Given this list of marker genes IL12B, IL23A, IFNAR1, EP300, STAT5B, C1QTNF4, MIR9-1, IL3 (interleukin 3), MST1, PRL, STAT4, CNTF, SOCS3, SOCS1, CISH, CRLF1, IL26, NAGLU, GGNBP2, JAK2, IFNA2, IL6ST, PKD1, NRTN, CSHL1, KIT, CRLF3, CSF2, ERCC6, WDR48, THPO, MIR149, MST1L, TNFRSF18, CSH1, IL9, PTPRD, IL15, STAT6, PRLR, CTF1, PTPN2, CSH2, FER, CSF1R, LIF, SOCS5, GH2, RAC1, CALM1, MIR125A, ADIPOR1, NEUROD1, PPARG, SH2B3, STAT5A, MIR221, EPHB2, HGS, CCL2, PKD2 (NCBI Gene Id 5311), JAK3, SOCS2, OCIAD2, IL12A, HMGA2, NOTCH1, PTK2B, NMI, LEPROT, IL20, PIBF1, IFNL3, HES5, USP1, IL31RA, IL21, CCR2, IL6R (NCBI Gene Id 3570), IFNG, IL10RA, CD40, INPP5F, EGF, IL5, TNFSF18, JAK1, MIR519A1, CLEC12B, IL23R, STAT1 (signal transducer and activator of transcription 1), MIR125B1, LEPR, F2, IFNAR2, IL18, IGF1, IFNL2, NF2, CAV1, F2R, CYP1B1, IFNB1, CCL5, PTPRC, PTPRT, MGAT5 (NCBI Gene Id 4249), MIRLET7E, MIR99A, BCL3 (BCL3 transcription coactivator, NCBI Gene Id 602), NLK, LEP, IL2, ELP2, TGFB1, FLT3, FGFR3, VHL, IFNL1, MIRLET7C, DAB1, IFNL4 (NCBI Gene Id 101180976), ERBB4, IL4, STAT3, EPO, IL7R, TNF, TNFRSF1A, CNOT7, PARP9, OCIAD1, IL15RA, CAMK2A, OSM (oncostatin M), CLCF1, PARP14, IL6, CENPJ, CTR9, GBP7, GH1, CRLF2, HES1, ARL2BP, TSLP, GADD45A, TYK2, PIGU, CSF2RA, STAMBP, DOT1L, IL10RB, IL10, SOCS6, GHR, MIR340, PTK6, PIAS1, STAT2, CSF2RB, MIR874 (NCBI Gene Id 100126343), MIR146A, here is a description of the gene set: studied in species Homo sapiens An intracellular signal transduction process in which STAT proteins (Signal Transducers and Activators of Transcription) convey a signal to trigger a change in the activity or state of a cell. The STAT cascade begins with receptor activation followed by activation of STAT proteins by kinases. It proceeds through STA dimerization and subsequent nuclear translocation of STAT proteins, and ends with regulation of target gene expression by STAT proteins. Human Gene Set: GOBP_CELL_SURFACE_RECEPTOR_SIGNALING_PATHWAY_VIA_STAT